Given this list of marker genes AICDA, APOBEC3C, HMGA2, TRIM28, APOBEC3G (apolipoprotein B mRNA editing enzyme catalytic subunit 3G), APOBEC3D, APOBEC3B, APOBEC3H, INPP5K, APOBEC3F, APOBEC3A, here is a description of the gene set: Any process that stops, prevents, or reduces the frequency, rate or extent of single stranded viral RNA replication via double stranded DNA intermediate. Human Gene Set: GOBP_NEGATIVE_REGULATION_OF_SINGLE_STRANDED_VIRAL_RNA_REPLICATION_VIA_DOUBLE_STRANDED_DNA_INTERMEDIATE studied in species Homo sapiens